The following is a description of a gene set: Genes down-regulated in comparison of untreated CD4 T cells at 0 h versus the untreated cells at 48 h. from publication Elo LL, Järvenpää H, Tuomela S, Raghav S, Ahlfors H, Laurila K, Gupta B, Lund RJ, Tahvanainen J, Hawkins RD, Oresic M, Lähdesmäki H, Rasool O, Rao KV, Aittokallio T, Lahesmaa R (PMID 20620947) studied in species Homo sapiens The aim of this dataset was to study in detail the transcription kinetics initiated by cytokine IL-4 in early differentiation of Th2 cells. Human Gene Set: GSE17974_0H_VS_48H_IN_VITRO_ACT_CD4_TCELL_DN, and this is the list of marker genes: DCPS, PLIN2, CCDC34, HNRNPC, TNFRSF8, CCNH, FANCB, NSD2, GGCT, FGF11, CREB3, ELP5, PARP9, RECQL4, CCT4, ACAA2, TEX30, CMSS1, TPM4, SASS6, DNAJC17, TPRG1 (NCBI Gene Id 285386), AIFM1, DNAAF10, MRPL18 (mitochondrial ribosomal protein L18), TBX21, WDR54 (WD repeat domain 54), MMACHC, LCP1, HDHD5, ETFB, TMEM120A, PDCD10, PARS2, GLB1, SORD, FAHD1, MRPS18B, EFNA4, NFXL1, NFE2L3, ORAI3, MRM2, PPP1R14B, PI4K2B, HCP5, SENP8, SDHAP1, MITD1, TRAP1, HNRNPLL, FAF1, ANGPTL6, GRHPR, COX8A, HEMK1, ATP5IF1, MPLKIP, BZW2, ZMYM6, EBP, ZDHHC13, GDI2, TDP1, CKLF, EXO1, ROMO1, IL2RB, LSM4, PRC1, PDHA1, TIGIT, METTL15, INPP4B, DNAJA3, GSTO1, UBL5, BCKDK, EFCAB3, FNTB, SAV1, C1GALT1C1, YWHAE, SGCB, CSTF3, CARS1, CHMP2A, SMG9, MICU1, INSIG2, HMCES (NCBI Gene Id 56941), DYM (NCBI Gene Id 54808), WDHD1, PAM, PIGM, IDH2, C9orf40, COPS8, TREX1, DPAGT1, INTS2, UCK2, MED20, GZMH, ZNF780A, ECI1, LSM2, METTL25B, LRRFIP2, VDAC1, RUVBL2, DCP1B, CSNK2A1, MPST, KIFC1, WRAP53, C5orf34, PRDX1 (peroxiredoxin 1), UBE2K, BAZ1B, ALKBH2, ZNF232, UMPS, GLIDR, NIF3L1, CHMP5, CEP152, CBR4, ATG7, FAM210A, SERAC1, HDAC1, RIF1, PSME3IP1, GLA, SYNE4, INTS6, CHSY1, TMEM165, SSU72, PAICS, MRPL37, CYB5B, SLC9A3-OT1, CRNKL1, PSMD8, MTHFD2, OARD1, ALCAM, LRRC42, TP53BP1, FAH, ANP32E, FAR2, LTA, SNRNP25, SNRPD3, GBE1, RMI1, CENPJ, NAA38, RHOF, BRIP1, CCNF, CORO1B, ATP5MF, MAD2L2, WDR3, LIMK2, KDELR2, MIR3142HG, ACY1, PCCB, TRNAU1AP, HPRT1, LEAP2, HMGB3, GCSAM, DHPS, SH2D5, RIMS3, GNGT2, COX6A1, KIF2A (NCBI Gene Id 3796), VPS26C, ATAD5, GM2A, MAP3K7CL, CCHCR1, OST4, PPID, HNRNPA2B1, KHDC1, TBC1D19, NEMP1 (NCBI Gene Id 23306), CDK2, RIBC2, CENPF